The following is a description of a gene set: FGFR2c ligand binding and activation Human Gene Set: REACTOME_FGFR2C_LIGAND_BINDING_AND_ACTIVATION studied in species Homo sapiens, and this is the list of marker genes: FGF1, FGF8, FGF16, FGF9, FGF17, FGF2, FGF20, FGF18, FGF5, FGF4, FGF6, FGF23 (NCBI Gene Id 8074), FGFR2